Given this list of marker genes CAMK4, MYH14, RGS16, IQGAP3, IQGAP1, MYO1D, STRN4, CNN3, MYO9B, ESR1, PHKG2 (NCBI Gene Id 5261), USP6, SLC9A1, VAMP2, PPP3CB, IQCF1, CAMK1G, KCNN3, SLC8A2, MYH1, MAP6, ADD1, PPP3CC, CACNA1S, RGS4, PCYT1A, IQCF2, RYR3, MAPKAPK3, MYO5C, AEBP1, TRPM3, CAMK2G, ADORA2A, UNC13B, ARPP21, RYR2, KCNH5, CAMK1, MYH10, MYH2, MYO1B (NCBI Gene Id 92451), CFAP221, EEF2K, UNC13C, PNCK, DDX5, TRPV1, ADCY8, SNTB1, FBXL2, MAPKAPK5, KCNQ2, KCNN1, MYH6, MKNK1 (NCBI Gene Id 8569), CDK5RAP2, MYO10, MYH4, CAMSAP1, TPRG1L, MYH8, TRPV5, MKNK2, SLC24A4, AKAP5, AKT1, IQCG (NCBI Gene Id 84223), MYH9, ATP2B2, EDF1, CASK, ORAI1 (ORAI calcium release-activated calcium modulator 1), NGFR, RGS2, TTN, CEP97, REM1, GAP43, ITPKC, AKAP12, MYO5A, OBSCN, PHKG1, PLA2G6, SYT7, SLC8A1, IQCF3, PHKA1, MYH3, MYO1E, ADCY1, SYT1, CNGA2, SPATA17, TRPV4, ATP2B4, EPB41, ASPM, IQCB1, PDE1C, FKBP8, ADD3, NOS3, MYO3A, MYLK (NCBI Gene Id 50483), MYLK2, MAPKAPK2, KCNH1, CTH, KCNQ3, MYO1A, INVS, SMTNL1, MYH11, CALD1, NDUFAF4, EWSR1, STRN3, ENKUR, CAMK1D, PHKB, SNTB2, PDE1B, MYH13, CAMKV, CNN1, CAMK2D, CAMK2B (calcium/calmodulin dependent protein kinase II beta), SCN2A, RIT2, IQGAP2, CEACAM1, NOS1, IQCF6, FAS, ITPKB, WFS1 (wolframin ER transmembrane glycoprotein), DAPK1, PHKA2, RASGRF2, EEA1 (early endosome antigen 1), CAMSAP3, KCNQ1, ATP2B1 (NCBI Gene Id 490), GEM, GRIN1, TRPM4, RYR1, MAP6D1, SLC8A3, MARCKS, MIP, NRGN (neurogranin, NCBI Gene Id 4900), MYH7, SNTA1, PCP4, MYH15, SPTBN1, MYO6, MYO7A, UBR4, CAMKK2, MYO1F, DAPK2, UNC13A, PLCB1, CAMKK1, PLCB3, BASP1, MYO1C, ADD2, CACNA1C, IQCF5, ATP5IF1, MYO5B (NCBI Gene Id 4645), SPHK1, CAMSAP2, SCN5A, NOS2, ADCY3, MYO1G, TJP1, MBP, MYO15A, PCNT, ATP2B3, PPP3R1, ACE, MARCKSL1, MAP2, SRY, PDE1A, KCNN2, SPA17, ITPKA, CAMK2A, RIT1, STRN, RGS1, SPTAN1, CNN2, KCNN4, RRAD, TRPV6, PPP3CA, here is a description of the gene set: Binding to calmodulin, a calcium-binding protein with many roles, both in the calcium-bound and calcium-free states. species: Homo sapiens Human Gene Set: GOMF_CALMODULIN_BINDING